Given this list of marker genes Ms4a2, Fcer2a, Fcer1a, Fcer1g, Fcgr4, here is a description of the gene set: studied in species Mus musculus Mouse Gene Set: GOMF_IGE_RECEPTOR_ACTIVITY Combining with an immunoglobulin of the IgE isotype via the Fc region, and transmitting the signal from one side of the membrane to the other to initiate a change in cell activity.